The following is a description of a gene set: Mouse Gene Set: GOBP_NEGATIVE_REGULATION_OF_CELL_ADHESION_MOLECULE_PRODUCTION studied in species Mus musculus Any process that decreases the rate, frequency or extent of cell adhesion molecule production. Cell adhesion molecule production is the appearance of a cell adhesion molecule as a result of its biosynthesis or a decrease in its catabolism., and this is the list of marker genes: Notch4, Apoa1, Aqp4, Ifnb1 (NCBI Gene Id 15977), Myocd, Notch1